Given this list of marker genes PLCB1, PER1, GHRL, PIK3R1, PDE3B, APPL1, TRERF1, OTOP1, TAF1, BGLAP, MAPK3, APC, NCOA5, BLVRB, FOXO3, GREB1L, HDAC1, EP300, FGF23, BMI1, PARP1, UCP1 (NCBI Gene Id 7350), TCF7L2, NUCKS1, FYN, RB1, OGT, NFKB1, SLC30A10 (NCBI Gene Id 55532), NR1D1, FBXO32, LBH, SOX10, PTPN1, KANK2, INS, WT1, OR51E2, BBS4, FKBP4, MAP1B, MBD5, IL23R, NCOA3, GRB7, SIK2, FOXH1, YWHAH, LEP (leptin), IL1B, MEF2C, PGR, MT3, PDE3A, RNF14, AKT2, RXRG, TP63, CSRP3, CTSD, UFM1, CCDC62, RXRA, MAPKAP1, PDPK1, CTSH, G6PC1, UBA5, MT-ND3, PTF1A, BCAS3, NPC1, SOCS3, PCK2, CSH1, TNS2, RPS6KB2, CYP24A1, CTSS, ATP1A2, GHSR, GLP1R, PIK3C2A, PADI2, UFL1, FSHR, TRIM24, MTCL2, DEFA1B, DUSP1, GPRIN3, CTSB, FOXO4, SSTR2, METTL21C, STAT3, SELENOS, PDK2, IGF1, ALAS1, VPS18, GRB14, SRC, RHOA, LYN, SCGB2A2, FLT3, CLDN18, HNF4A, PAGR1, CPEB1 (NCBI Gene Id 64506), CRHR2, FAT1, CYP11B2, WDTC1, SSTR1, MDM2, SYAP1, NCOA4, PRKCA, CYP11B1, AKR1C4, CCL21, NODAL, CCR7 (C-C motif chemokine receptor 7), SCNN1A, LPIN1 (NCBI Gene Id 23175), TBX2, GATA1, NR2E1, UMODL1, HDAC6, TRIB3, GSK3A, NR5A1, HEYL, ABCB1, PAK1, LPIN2, GRB2, SFR1, FOSB, AR, MIR107, URI1, SLC2A4, NR3C1 (NCBI Gene Id 389335), AHSG, CACNA2D3, CYP26C1, CUL7, REN, QRFPR, LANCL2, SOS1, ISL1, GTF2H1, ZNF764, TRIM68, RARRES2, ANXA1, ECHDC3 (NCBI Gene Id 79746), SAFB2 (scaffold attachment factor B2), RELA, AVPR1A, CALCOCO1, ESRRA, FBN1, ERRFI1, PML, TRIM16, LHCGR, HDAC2, ABHD2, VPS54, CSNK2B, SLC26A6, GKAP1, GPR150, DAXX, SLC34A1, INSR, NR2C1 (NCBI Gene Id 7181), EZH2, SLC2A8, MTOR, ZBTB7B, GH2, CRY1, GPLD1, IGF1R, CGB3, SSTR4, ESRRG, CSH2, CCNA2, PIK3R3, SCNN1D, CEACAM1, ALDH1A2, TYK2, SCNN1G, ADTRP, GNG2, HSPA1A, NR1H2, SP1, KMT2D, SCX, EIF4EBP2, CAPN10, NR0B1, STAT6 (NCBI Gene Id 6778), TOP1, PRKAA2, ACSL1, PIP4K2C, ADIPOR1, VDR, TFAP4, HMGCS2, VWA2, APPL2 (NCBI Gene Id 55198), DEFA1, BCAR1 (BCAR1 scaffold protein, Cas family member), NKX3-1, INHBB, OXTR, WNT1, PCSK9, GSTP1, AGT, RXFP1, SREBF1, GH1, BMAL1 (basic helix-loop-helix ARNT like 1), ACOD1, KDM5D, PIP4K2A, FUT1, PROKR2, RNF6, SMARCC1, ROCK2, GPR22, CRKL, CYP11A1, ATP1A3, MAP3K7, CRH (corticotropin releasing hormone), HSPA8, ASIP, SOCS7, ERFE, CYP7B1, KDM3A, PLA2G2A, SORL1, FFAR3, PXN, FOXP1, PRL, ZBTB7A, TCF21, NCOR1, GLP2R, SCGB2A1, RAMP1, ZMIZ1, KDM4C, FBXW8, NPPA, GCGR, GRB10, FGB, RAC1, NONO, CPEB2, CTBP2 (NCBI Gene Id 87435), GATA6, SLC27A1, NCOA2, EPHA8, SOCS1, PIM1, MYO5A, GOT1, PMEPA1, AKR1C3, NCOA1, SNW1, FAM107A, HDAC3 (NCBI Gene Id 8841), PAX8, UBE3A, CGA, GHRHR, SERPINF1, RAMP3, GNB1, ADIPOR2, HCN2, LEPR, PIP4K2B, AKT1, RWDD1, INSRR (NCBI Gene Id 3645), PRKAA1, HSPA1B, DDRGK1, NPFFR2, SST, LATS1, UGCG, RAB13, SHOC2, NR4A3, PIK3R2 (NCBI Gene Id 5296), PRAME, SIRT1, AIFM1, CBX3, PPP5C, MIR15B, RAF1, NKX6-1, C1QTNF12, CA2, PAQR8, TADA3, HSF1, ACTN2, UCN2, RDX (NCBI Gene Id 5962), SKP2, SORBS1, EFNA5, AGRP, PRMT2, ATP2B1, PPP3CA, LEPROTL1, RHOXF1, THRA, CARM1, KDM1A, WBP2, RARG, HDAC9, IGFBP1, OSBPL8, PTGDR2, KLF9, SOCS2, CAV1, FOXC2, TBC1D4, CUL3, PELP1, ACACA, GAB1, EDNRA, EEF2K, PAQR7, ACE, NR1H4, AVPR2, PRKCZ, IDE, LATS2, RAB10, CFL1, CRK, CREBRF, CNOT1, TNC, GRIA1, NOTCH1, IRS2, PRKCB, RAP1GDS1, PKLR, RANGAP1, PRKD1, MIR195, ATP5F1A, SGK1, GCG, YWHAG, SMARCA4, P2RY4, TNFSF4, PHB2, LONP1, EGLN2, GPR21 (G protein-coupled receptor 21), CYP26A1, FOS, SRSF5, PRCP, CYBA, PID1, GCLM, PRKCI, HCRTR1, CASP9, TRARG1, CPS1, ESR2, POU4F2, JAK2, TFPI, GPHB5, TRIM72, PHEX, SLC25A33, ROCK1, UFSP2, IRS1, IGFBP2, PRKAR1A, SLC27A4, RXFP2, AVPR1B, PTH, GPR173, CALR (calreticulin), CDK12, NAMPT, VAMP2, PTPRE, RXRB, CAV2, AXIN2, BCAR3, AGTR2, MIR143, PHB1, MED1, TBX1, HDAC5, DNAAF4, PRLR, SLC5A5, FER, CSF2RA, SHC1, THRB, EPRS1, GNAS, NSMF, GNRHR2, SP100, TRIP4, TAF7, LHB, PRKDC, BRCA1, CCL19, MYO1C, ASS1, DDX54, JAK1, DDX17, PTPRJ, SRD5A1, CST11, SNX5, PLPP1, SESN3, USP26, STXBP4, PROKR1, DAB2, ARID5A, GNRHR, RAN, DDIT4, RAB8A, RHOQ, STAT5A, KAT2B, DENND4C, PKM (pyruvate kinase M1/2), SOST, BRD8, GDF15, PPARD, UCP3, STAT1, AGTR1, BAIAP2, HNRNPU, JAK3, AHCYL1, VPS11, TSC2, IGF2, CYP26B1, UCP2, INSIG1, MZB1, ADIPOQ, FOXO1, ZNF536, PLA2G1B, ESRRB, ADCY8 (adenylate cyclase 8), PTGER4, C2CD5, TGFB1, STRN3, PGRMC2, HCRTR2, PPARGC1B, KANK1, PTK2, CRY2, PTPN11, NFE2L2, MN1, ACTN4, DNAI1, SLC39A14 (NCBI Gene Id 23516), FOXA1, P2RY6, SSTR3 (NCBI Gene Id 6753), SLIT2, EDN1, NR1H3, LPIN3, PKN1 (protein kinase N1), FAM114A1, TMF1, MIR103A1, TGIF1, ZFP36L1, SLC9A1, WNT10B, ADRA2A, SGCB (NCBI Gene Id 6443), CNOT9, NCL, AKR1C2, STC1, NCOR2, SLIT3, PCK1, RAMP2, MAS1, ROBO2, AKAP8, NR4A1, RARA, DDX5, CREB1, PIAS2, RAB31, SLC22A12, STAT5B, ADCY6, SCNN1B (sodium channel epithelial 1 subunit beta), XBP1, NPFFR1, NR1D2, DEFA3, NR3C2, AP3S1, NCK1, PTGFR, BCL2L11, CFLAR, SMYD3, PRKCD, HMGA2, RARB, INHBA, SFRP1, PTGER2, CSHL1, SAFB, USP8, MIR145, MGARP, CACNA1H, UBR5, PTPN2, INPP5K, SOS2, TRH, CTSL, EIF4E, SNAI2, ZDHHC7, SSTR5, ZNF106, NR4A2, ETNPPL, SERPINB9, SRARP, FUT7, INSIG2, NPAS4, MKKS, USF1, ESR1, GPER1, PNPLA3, ITGB3, NR2E3, MIR493, CYP27B1, TSHR, OCSTAMP, MYOD1, PRKCE, CSK, CRHR1, PPARG, PPARA, AQP1, ATP1A1, FBP1, MSTN, SERPINA12, ZNF592, CCKAR, SHQ1, BBS2, MIR1271, CRHBP, PRKACA, ZFP36L2, CLOCK, ENPP1, GCK (NCBI Gene Id 2645), ZNF366, LMO3, PARK7, UCN3 (NCBI Gene Id 114131), MIR208A, NR5A2, CDC6, KBTBD2, POR, LEPROT, USO1, NDEL1, SH2B2, ZFP36, KLF2, OSTN, IGFBP7, REST, ANKRD13C, AKR1C1, GSK3B, PDK4, UBE2L3, IRS4, AGTRAP, HRAS, CNOT2, GCLC, RBM4, PTGDR, CAMK2A (NCBI Gene Id 815), FECH, GHR, MAPK1, PRKCQ, DDR2, PHIP, RBFOX2, COL6A1, PIK3CA, ASXL1, RPS6KB1, RBX1, DHRS3, NEDD4, here is a description of the gene set: Human Gene Set: GOBP_CELLULAR_RESPONSE_TO_HORMONE_STIMULUS species: Homo sapiens Any process that results in a change in state or activity of a cell (in terms of movement, secretion, enzyme production, gene expression, etc.) as a result of a hormone stimulus.